The following is a description of a gene set: from publication Derbinski J, Gäbler J, Brors B, Tierling S, Jonnakuty S, Hergenhahn M, Peltonen L, Walter J, Kyewski B (PMID 15983066) species: Homo sapiens Genes up-regulated in medullary thymic epithelial cells (mTEC): CD80 high versus low. Human Gene Set: GSE2585_CD80_HIGH_VS_LOW_MTEC_UP Gene expression in different thymic stromal cells and subsets thereof was analyzed in 6-12 week old wild type (C57BL/6) and Aire knock-out (mixed background) mice. Thymic stromal cells were purified by sequential enzymatic digestion (collagenase, collagenase/dispase and trypsin) followed by gradient centrifugation and FACS sorting. Sort criteria were as follows: dendritic cells (CD11c+, F4/80 -), macrophages (F4/80+, CD11c-), cTECs (CD45–/lo, CDR1/Ly51+, Ep-CAM+) and mTECs (CD45–/lo, CDR1/Ly51–, Ep-CAM+). mTECs of wild-type and Aire knock-out mice were further subdivided according to CD80 expression levels. For microarray analysis total RNA from thymic stromal cell samples of two independent experiments was pre-amplified and biotinylated by two rounds of cDNA synthesis and in vitro transcription. Fluorescence readings were evaluated by using Microarray Suite 5.0 software., and this is the list of marker genes: EREG, SEMA3E, B4GALT2, OR5D18, NEUROD6, PROB1 (proline rich basic protein 1), SLC7A4, SCT, SSTR4, ZNF12, STAU2, KRT20, HSBP1L1, PDE1A, CAMKK1, KLHL41, PDZD9, FLG, FGF17, ASGR2, THSD7A, DDAH1, YJEFN3, SYCP1, MLXIPL, BHLHE22, FYTTD1, TPH1, STYXL2, GATA6, LOX, IL36RN, HSFY2, HSPB1, DEFB106B, ABHD14B, NLRP9, LAPTM4B, RAD51B, FUT1, C9orf43 (chromosome 9 open reading frame 43), ALDH1L2, CA6, RND2, NRCAM, HYLS1, ADCY2, MAX, KRT14, SEL1L2, CDH18, IL17RB, PRND, TPTE, CC2D2B, BCAS1, RSPH6A, GRIK1, RESF1, GKN2, TSGA10, SDR16C5, TMEM182, PKNOX2 (NCBI Gene Id 63876), MIDN, VSTM2A, CFAP276, NKX2-6, SLC10A2, LAMP5, C1R, CDH20, OR51E1, NAA16, ABCA12, HRC, ZNF532, JPH1, ASPHD2, SAMD5, COL17A1, SLC17A1, ASB16 (ankyrin repeat and SOCS box containing 16), EFHC2, CIB2, F13B, CYP27B1, GUCY2D, SAXO2, GULP1, ATP1A3, SCARNA13, GALNT13, NT5C3B, LARGE2 (LARGE xylosyl- and glucuronyltransferase 2), FAT1, MAK, ADAM7, CMTM8, LPAR4, FABP9, C2CD2, KLK12, SV2C, MAPK4, CYP11B1, MACC1, VEGFD, HNRNPU, KRT85, C9orf78, KRT33A, ENAM, HYAL4, SH2D4B, SNHG12, NNMT, REEP1, UBE2J1, ERICH2, PCDH9, ITM2C, GPR183, MMP20, PRCC, COL27A1, CLEC14A, PREX2, HAPLN2, LIPH, FBP2, ACTRT1 (actin related protein T1), FAM3B, DOCK3 (NCBI Gene Id 1795), ADRA1B, HJV, SCCPDH, TEKTL1, TM9SF3, NECAB1, HAND1, FOXA2, SHROOM3, ADAM32, INHBE, ANO9, CPZ, MAGEA11, CLEC5A, TRPM3, DLG5, MPP2, DNMT3L, POLR1C, SAMD12, EMD, TOM1L1, UQCRHL, NRG4 (neuregulin 4), HLF (HLF transcription factor, PAR bZIP family member), DCDC2, ILF2, TMEM252, GPRIN2, METTL24, OS9, IER5L, PRKG1, PPFIA3, HOXB13, PLEKHH3, DEFB116, CLVS1, FABP7, PKDCC, CCDC150, PTBP3, HEY2, SLC6A3, ZNF691, C4BPA, FSHB, SHISA3, SYT17, GPM6B, TAL2, LDHC, RILP, ZSWIM4, DMRT2, IRS1, PRKD1, SLC17A6, GCNT3, IRX5, THEM5, SCTR, NDP, RAMP2, CSTA